Given this list of marker genes A4GNT, BMP1, ASPRV1, HTR3A, SCGB3A2, EPB41L3, TMEM44, CPPED1, LDHD, SGCZ, OR2C3, FAM47B, NDOR1, CASC22, GAMT, CFB (NCBI Gene Id 629), IQUB, GAL3ST4, SLC7A7, CSTL1, TLCD2, ITGA10, HSD17B3, DDA1, ERBB2, APC2, ZNF236-DT, IQCA1, CCDC13-AS1, CIMAP1A, KAZN, FBXW4P1, CABP2, ISX, ALG12, SUGT1P3, ENSG00000291065, TIGD3, CLIP2, APOA5, SMIM31, PTPRN, BEND7, MCOLN1, TSC22D4, LSMEM2, VSIG4, CFAP65, LILRA3, DEFB1, PDGFRL, MELTF-AS1, WNK3, LINC01093, LINC00698, CFAP100, SMUG1, FAM167A-AS1, ZACN, TMEM176A, PDZRN3, FRY-AS1, FANCC, SPPL2C, PRKG1, DOLPP1 (dolichyldiphosphatase 1), BRICD5, LINC02223, LGI1, KXD1, MAST1, HSPB7, MAGEL2, SNCG, CES1, FMO9P, CD14, ITGB6, CDK5R2, CCDC158, DUSP13B, PPP1R14A, CAVIN3 (NCBI Gene Id 8990), NUDT22, AMOT, ASB16-AS1, C1orf159, PCDH17, HCK, LINC00896, MMAB, SGO2, ZBTB8B, CIMAP1D, GHRL, ZC3H3 (zinc finger CCCH-type containing 3), DMRTA1, ANKS6, WDR27, PLEK, TGM7, RPAP1, PLA2G6 (phospholipase A2 group VI), RAB5C (NCBI Gene Id 5878, RAB5C, member RAS oncogene family), SOX8, LMF2, GRAMD1B, VCX2, EVPL, IGLV4-60, FAM66D, SEPTIN7P11, PILRA, HSD17B6, RP9P (RP9 pseudogene), MAB21L3, TRBV10-2, WRAP73, SPINK7, STAB2, H2BW2, SLC22A9, CLEC10A, PAGE1, SFXN5, MECR (mitochondrial trans-2-enoyl-CoA reductase), IFI30, SNTN, DDX54, HAMP, NOL4L, C16orf74, GUSBP2, G0S2, FAM78A, PNMA2, SNCAIP, PNMA8A, GASK1B, SAMD10, ZFYVE28, MTMR11, IGLON5, PGAM2, MAGI1-IT1, FREM3, ADCY5, KIFC2, CLEC4E, TMEM254-AS1, CABP4, JOSD2, SMG6, AOC1, SLC38A4-AS1, PARP3, TTC9B, CRACDL, RNF207, GARS1-DT, APRG1, OSBPL7, CD163, NXF5, IGHD, PRR22, SS18, FABP3, NECTIN2, LILRB1, CDKN2B-AS1, ENSG00000271776, TREML3P, LILRB2, GTSF1L, C1QTNF2, PGAP3, LY6G6E, CORIN, SRSF12, ABCB9, ABCA2, CLEC7A, ADGB, PROSER3, PGC, H1-9P, GJA5, MGAT4EP, LINC00955, ENSG00000224090, here is a description of the gene set: Human Gene Set: GSE17974_CTRL_VS_ACT_IL4_AND_ANTI_IL12_0.5H_CD4_TCELL_UP The aim of this dataset was to study in detail the transcription kinetics initiated by cytokine IL-4 in early differentiation of Th2 cells. Genes up-regulated in comparison of untreated CD4 T cells at 0 h versus the cells treated with IL4 and anti-IL12 at 0.5 h. from publication Elo LL, Järvenpää H, Tuomela S, Raghav S, Ahlfors H, Laurila K, Gupta B, Lund RJ, Tahvanainen J, Hawkins RD, Oresic M, Lähdesmäki H, Rasool O, Rao KV, Aittokallio T, Lahesmaa R (PMID 20620947) species: Homo sapiens